Given this list of marker genes TSPAN7, G3BP1, CEBPB, GARS1, IGF2R, ACP3, CAMK2N2, GCNT1, FBLN5, CDK2AP1, LOXL1, UPP1, IL15, TIAM1, LMO1, MED26, TAX1BP3, ADH7, PFN2, EMILIN1, MACROH2A1, TGFB1, ASNS, CAMK2A, JUN, NDST1, GABPB1, ARF4, NNMT, ENAH, SLC7A1, here is a description of the gene set: Genes corresponding to the histamine response network. species: Mus musculus Human Gene Set: POS_HISTAMINE_RESPONSE_NETWORK We previously showed that transgenic enhancement of histamine production in B16-F10 melanomas strongly supports tumor growth in C57BL/6 mice. In the present study, gene expression profiles of transgenic mouse melanomas, secreting different amounts of histamine, were compared by whole genome microarrays. Array results were validated by real-time PCR, and genes showing histamine-affected behavior were further analyzed by immunohistochemistry. Regulation of histamine-coupled genes was investigated by checking the presence and functional integrity of all four known histamine receptors in experimental melanomas and by administering histamine H1 receptor (H1R) and H2 receptor (H2R) antagonists to tumor-bearing mice. Finally, an attempt was made to integrate histamine-affected genes in known gene regulatory circuits by in silico pathway analysis. Our results show that histamine enhances melanoma growth via H1R rather than through H2R. We show that H1R activation suppresses RNA-level expression of the tumor suppressor insulin-like growth factor II receptor (IGF-IIR) and the antiangiogenic matrix protein fibulin-5 (FBLN5), decreases their intracellular protein levels, and also reduces their availability in the plasma membrane and extracellular matrix, respectively. Pathway analysis suggests that because plasma membrane-bound IGF-IIR is required to activate matrix-bound, latent transforming growth factor-beta1, a factor suggested to sustain FBLN5 expression, the data can be integrated in a known antineoplastic regulatory pathway that is suppressed by H1R. On the other hand, we show that engagement of H2R also reduces intracellular protein pools of IGF-IIR and FBLN5, but being a downstream acting posttranslational effect with minimal consequences on exported IGF-IIR and FBLN5 protein levels, H2R is rather irrelevant compared with H1R in melanoma. from publication Pos Z, Wiener Z, Pocza P, Racz M, Toth S, Darvas Z, Molnar V, Hegyesi H, Falus A (PMID 18339882)